The following is a description of a gene set: The chemical reactions and pathways resulting in the formation of a nucleoside monophosphate, a compound consisting of a nucleobase linked to a deoxyribose or ribose sugar esterified with phosphate on the sugar. Human Gene Set: GOBP_NUCLEOSIDE_MONOPHOSPHATE_BIOSYNTHETIC_PROCESS species: Homo sapiens, and this is the list of marker genes: AMPD1, RFK, DGUOK, TYMS, IMPDH2, PAICS, GMPS, DHODH, UPP2, AMPD3, PRPS1, ADSS1, HPRT1, AMPD2, DCTD, NUDT2, UMPS, CAD, UPP1, ENTPD8, APRT, GART, TK1, ADSS2, ADA, ADSL, DCK, PFAS, IMPDH1, PRPS1L1, TK2, SHMT1, UPRT, PPAT, PRPS2, UCK1, CDA (NCBI Gene Id 978), ATIC, UCK2, CMPK1, ADK, DUT, UCKL1